Given this list of marker genes Prelid3b, Pitpnc1, Prelid1, Prelid3a, Pltp, Triap1, Prelid2, here is a description of the gene set: studied in species Mus musculus Removes a phosphatidic acid from a membrane or a monolayer lipid particle, transports it through the aqueous phase while protected in a hydrophobic pocket, and brings it to an acceptor membrane or lipid particle. Phosphatidic acid refers to a glycophospholipids with, in general, a saturated fatty acid bonded to carbon-1, an unsaturated fatty acid bonded to carbon-2, and a phosphate group bonded to carbon-3. Mouse Gene Set: GOMF_PHOSPHATIDIC_ACID_TRANSFER_ACTIVITY